Given this list of marker genes CDO1, NR1D2, IL11RA, AQP1, HSD17B11, LXN, MT1F, TMEM176B, TMEM176A, PMP22, DHRS7, GADD45A, PDGFRA, TIMP3, DDIT3 (NCBI Gene Id 92982), GBE1, DCN, PRRX2, ALDH1A1, NGEF, here is a description of the gene set: Genes up-regulated in NIH3T3 cells (fibroblasts) transfrormed by expression of constitutively active (Q63L) form of RHOA off plasmid vector; their expression did NOT reverted completely after treatment with Y27632, an inhibitor of ROCK proteins. Human Gene Set: BERENJENO_TRANSFORMED_BY_RHOA_FOREVER_UP We have used microarray technology to identify the transcriptional targets of Rho subfamily guanosine 5'-triphosphate (GTP)ases in NIH3T3 cells. This analysis indicated that murine fibroblasts transformed by these proteins show similar transcriptomal profiles. Functional annotation of the regulated genes indicate that Rho subfamily GTPases target a wide spectrum of functions, although loci encoding proteins linked to proliferation and DNA synthesis/transcription are upregulated preferentially. Rho proteins promote four main networks of interacting proteins nucleated around E2F, c-Jun, c-Myc and p53. Of those, E2F, c-Jun and c-Myc are essential for the maintenance of cell transformation. Inhibition of Rock, one of the main Rho GTPase targets, leads to small changes in the transcriptome of Rho-transformed cells. Rock inhibition decreases c-myc gene expression without affecting the E2F and c-Jun pathways. Loss-of-function studies demonstrate that c-Myc is important for the blockage of cell-contact inhibition rather than for promoting the proliferation of Rho-transformed cells. However, c-Myc overexpression does not bypass the inhibition of cell transformation induced by Rock blockage, indicating that c-Myc is essential, but not sufficient, for Rock-dependent transformation. These results reveal the complexity of the genetic program orchestrated by the Rho subfamily and pinpoint protein networks that mediate different aspects of the malignant phenotype of Rho-transformed cells. from publication Berenjeno IM, Núñez F, Bustelo XR (PMID 17213802) studied in species Mus musculus